Given this list of marker genes Urad, Nt5c, Gda, Nt5c1a, Dnph1, Urah, Ada, Xdh, Pnp, Nt5c2, Uox, here is a description of the gene set: The chemical reactions and pathways resulting in the breakdown of purine deoxyribonucleoside monophosphate, a compound consisting of a purine base linked to a deoxyribose sugar esterified with phosphate on the sugar. Mouse Gene Set: GOBP_PURINE_DEOXYRIBONUCLEOSIDE_MONOPHOSPHATE_CATABOLIC_PROCESS species: Mus musculus